The following is a description of a gene set: studied in species Mus musculus Mouse Gene Set: WP_FOCAL_ADHESION_PI3KAKTMTOR_SIGNALING_PATHWAY Focal adhesion: PI3K-Akt-mTOR signaling pathway, and this is the list of marker genes: Creb3l2, Gngt1, Gys2, Jak1, Ikbkb, Fgf10, Fn1, Gys1, Pdgfd, Ngfr, Rptor, Itgb8 (NCBI Gene Id 320910), Fgfr3, Fgfr1, Rab11b, Pik3r1, Crtc2, Spp1, Pik3r5, Eif4e, Fgf14, Itgb6, Map2k2, Ifna7, Itga5, Gh, Sos1, Itgax, Itgam, Acaca, Fgf3, Vegfb, Ppp2r1b, Tnn, Vegfd, Reln, Pik3ca, Tnxb, Vegfc, Met, Irs3, Lamb1, Pelo (pelota mRNA surveillance and ribosome rescue factor), Col11a2, Ddit4, Col11a1, Flt1, Itgb4, Itgb1, Pik3c2g, Foxo3, Rab10, Itga3, Thbs3, Itgav, Pik3r2, Col5a2, Mlst8, Fgf16, Itga2b, Rps6kb1, Il6ra, Tek, Cab39, Fgf9, Ifnab, Akt3, Ifna4, Ppp2r5a, Itga4, Grb2, Itga10, Fgfr2, Prkaa2, Eif4b, Epo, Itga6, Pik3cd, Ppargc1a (peroxisome proliferative activated receptor, gamma, coactivator 1 alpha), Casp9, Gngt2, Epas1, Gnb1, Pdgfrb, Lipe, Itgb5, Gng13, Il2, Comp, Ghr, Creb3l3, Ifna2, Kit (KIT proto-oncogene receptor tyrosine kinase), Akt2, Ifnar2, Ins2, Rab2a, Eif4e2, Fgf7, Pdgfb, Stk11, Map2k1, Gnb4, Lpar6 (NCBI Gene Id 67168), Ppp2r5e, Pik3c2b, Creb1, Nras, Ngf, Fgf21, Lpar4, Ifna11, Ppp2ca, Nos3, Col5a1 (collagen, type V, alpha 1), Itga9, Kitl, Pfkfb1, Tcl1b1, Akt1, Gng2, Thbs1, Thbs4, Ifna9, Osm, Itgal, Atf2, Col5a3, Foxo1, Itgb2, Itga11, Pfkfb4, Creb3l4, Egf, Ppp2cb, Fgf6, Bad, Gng12, Hif1a, Csf3, Vwf, Ptk2, Hif3a, Cdkn1a, Ibsp, Gng5 (G protein subunit gamma 5), Itga7, Ifnb1, Lamc2, Nos1, Lama5, Itgb3, Osmr, Prlr, Itgad, Ppp2r2c, Igf1, Rps6, Pfkfb3, Csf3r, Creb3l1 (NCBI Gene Id 26427), Mapk3, Irs4, Lama3, Col1a1, Tsc2, Vegfa, Pik3c2a, Lama1, Tcl1b4, Lamb2, Fgf4 (NCBI Gene Id 14175), Irs2, Il4ra, Ppp2r2d, Mtor, Fgf8, Pik3r4, Jak2, Rab8a, Chrm1, Ppp2r5c, Pgf, Pdgfra, Slc2a4, Epha2, Ifnar1 (NCBI Gene Id 15975), Slc2a2, Vtn, Cab39l (NCBI Gene Id 75621), Itga2, Hgf, Insr, Il7r, Rheb, Fgf15, Gng10, Col1a2, Pten, Fgf18, Ifna1, Angpt4, Ifna6, Atf4, Slc2a3, Lpar1, Pdgfc, Mapk1, Ppp2r3a, Mtcp1, Gng3, Col4a2, Itga8, F2r (coagulation factor II thrombin receptor), Ifna13, Rab14, Thbs2, Gnb3, Irs1, Il2ra, Col4a4, Phlpp2, Gng7, Lamb3 (NCBI Gene Id 16780), Nos2, Tbc1d1, Il2rb, Hsp90aa1, Fgf17, Ins1, Kdr, Tnc, Fgf12, Col6a2 (collagen, type VI, alpha 2), Prkaa1, Foxa1, Fgf13, Phlpp1, Chad, Kras, Fgf20, Angpt2, Pfkfb2, Raf1, Slc2a1, Hras, Csf1, Lpar5, Eif4ebp1 (eukaryotic translation initiation factor 4E binding protein 1), Lpar2, Ifna5, Gng4, Atf6b, Gng11, Ifna14, Tnr, Lamc3, Gsk3b, Col4a1, Fgf2, Fgf22, Angpt1, Egfr, Igf1r, Ikbkg, Cdc37, Pdpk1, Itgae, Col2a1, Ppp2r5b, Fgfr4, Jak3, Ppp2r3c, Pik3cg, Chrm2, Epor, Tsc1, Tcl1, Flt4, Pdgfa, Ppp2r5d, Lama2, Lpar3, Col4a6, Lamc1, Col3a1, Efna2, Il3ra, Rps6kb2, Cdkn1b, Hsp90ab1, Prl, Fgf1, Efna3, Ppp2r3d, Mdm2, Itgb7, Creb5, Srebf1, Lama4, Eif4e1b, Hsp90b1, Creb3, Gng14, Pik3cb, Csf1r, Efna5, Gng8, Ppp2r2b, Elavl1, Efna4, Ppp2r1a (protein phosphatase 2, regulatory subunit A, alpha), Efna1, Il2rg, Strada, Ulk1, Akt1s1